Given this list of marker genes CYP1A1, ARNT2, CYP2C8 (cytochrome P450 family 2 subfamily C member 8), CYP2D6, CYP2F1, AHRR, CYP3A7, CYP2C19, AHR, CYP2C9, CYP2A7, CYP3A43, CYP2A13, ARNT, CYP1A2, CYP3A5, CYP3A4, CYP2S1, CYP2E1, CYP2J2, CYP2W1, CYP2C18, CYP2A6, CYP2B6, here is a description of the gene set: Reactome Pathway: Xenobiotics part of: Cytochrome P450 - arranged by substrate type species: Homo sapiens Of the 50 microsomal CYPs, 15 act on xenobiotics. They all possess wide substrate specificity to cater for most foreign compounds that find their way into the body.